Given this list of marker genes Apoh, Apoa4, Pnpla2, Daglb, Abhd5, Apoa5 (apolipoprotein A-V), Apoc2, Gpld1, Sorl1, Apoc2l, Aadac (arylacetamide deacetylase), Plin5, Fgf21, Apoc3, Pik3cg, Ldlr, here is a description of the gene set: species: Mus musculus Mouse Gene Set: GOBP_REGULATION_OF_TRIGLYCERIDE_CATABOLIC_PROCESS Any process that modulates the frequency, rate, or extent of the chemical reactions and pathways resulting in the breakdown of triglyceride.